Given this list of marker genes Ces1e, Lipn, Cel, Ces1a, Lipo1, Ces1g, Lipo4, Lipo3, Ldah, Gm8978, Ces1h, Lcat, Ces1f, Lipo2, Lipe, Ces1b, Lipa, Ces1d, Ces1c, here is a description of the gene set: species: Mus musculus Catalysis of the reaction: a sterol ester + H2O = a fatty acid + a sterol + H+. Mouse Gene Set: GOMF_STEROL_ESTER_ESTERASE_ACTIVITY